The following is a description of a gene set: Severe combined immunodeficiency A type of primary immune deficiency that is characterized by a more severe defect in both the T- and B-lymphocyte systems. Human Gene Set: HP_SEVERE_COMBINED_IMMUNODEFICIENCY studied in species Homo sapiens, and this is the list of marker genes: RMRP (RNA component of mitochondrial RNA processing endoribonuclease), MTHFD1 (NCBI Gene Id 4522), CHD7, LIG4, PI4KA, CD3D, ADA, IL2RG, PGM3, XRCC4, TTC7A, IL7R, DCLRE1C, POLD3, PNP, PRKDC, RAG2, AK2, RAG1, JAK3, EXTL3, BCL11B